The following is a description of a gene set: Human Gene Set: GOMF_STRUCTURAL_CONSTITUENT_OF_SKIN_EPIDERMIS studied in species Homo sapiens The action of a molecule that contributes to the structural integrity of an epidermal cutaneous structure., and this is the list of marker genes: KRT81, KRT6B, KRT36, KRT83, FLG, PNPLA1, KRTAP1-3, KRT76, KRT7, KRT73, KRT71, KRT5, KRT75, KRT3, KRTAP5-8, KRT84, KRT78, KRT10, KRT79, KRT2, KRT6A (NCBI Gene Id 93086), KRT6C, KRT1, KRT77, KRT4, KRT80, PI3, KRT74, KRT72, SPRR1A, LORICRIN, KRT82, KRT86, TUFT1, KRT85, SPRR2E (NCBI Gene Id 6704), PKP1